Given this list of marker genes Vegfa, Tnf, Btbd7, Fgfr2, Fgf10, Agt, Cav3, Bcl11a, Shh, Cpe, Sox8, Sfrp1, Bmp7, Six4, Pgf, Rtn4, Gdnf, Hoxd13, Grem1, Hnrnpk, Fgf7, Il1b, Pax8, Pdgfa, Mdk, Map3k13, Tacstd2, Pax2, Ar, Sox9, Cdh1, Agtr1b, Nog, Lgr4, Fgfr1, Pdgfra, Six1, Mecp2, Fkbpl (NCBI Gene Id 56299), Met, Wnt2b, Sulf1, Snai2, Esr1, Rxra, Agtr2, Hoxb7, Hgf, Six2, Lhx1, Ntn4, Etv5, Lrrk2, Sirt6, Abl1, Phb2, Tgfb1 (NCBI Gene Id 21803), Shox2, Agtr1a, Ctnnb1, Wnt5a, Smo (NCBI Gene Id 319757), Sall1, Bmp4, Maged1, Wnt2, here is a description of the gene set: studied in species Mus musculus Any process that modulates the rate, frequency, or extent of branching morphogenesis, the process in which the anatomical structures of branches are generated and organized. Mouse Gene Set: GOBP_REGULATION_OF_MORPHOGENESIS_OF_A_BRANCHING_STRUCTURE